The following is a description of a gene set: species: Homo sapiens Genes containing one or more binding sites for (ELF5) in their promoter regions (TSS -1000,+100 bp) as identified by GTRD version 20.06 ChIP-seq harmonization. Human Gene Set: ELF5_TARGET_GENES from publication Yevshin I, Sharipov R, Kolmykov S, Kondrakhin Y, Kolpakov F (PMID 30445619), and this is the list of marker genes: SPRYD3, MON2, PCDHGB1 (NCBI Gene Id 56104), CCDC90B, CCDC137, INTS13, DYNLRB2, FRG1, EXD3, LIMD1-AS1, PCYT1A, ZMAT3, TRIP4, TMEM87A, UBFD1, VTCN1, MRPL52, E2F6, SLC39A9, TBPL1, RAD50, SLC7A7, SMG7-AS1, PPP1R9B, ZBTB37, PYROXD2, GPBP1 (NCBI Gene Id 65056), PHF8, ZNF569, GANC, GIHCG, AXDND1, SCAND1, ATP2B4 (NCBI Gene Id 54594), PYROXD1 (NCBI Gene Id 79912), SUDS3, NAIF1, METTL6, GARS1, SNHG11, TUT1, ERP44 (NCBI Gene Id 23071), RPL37, CHCHD5, TMEM242, OXR1-AS1, EIF2S1, CDC42SE1, MYL12B, COX5B, TTC14, CDK18, DHX33-DT, UBC, SNRPB2, CDK6-AS1, DNAI1, CTDSP2, ADPRHL1, RPL29, MOCS3, ERBIN, DHFR2, LINC01132, KCTD5 (NCBI Gene Id 91152), LIMA1, THRB-AS1, LINC02518, CTSD, LYSMD1, ZNF823, DPM1, ESYT1, DMTF1-AS1, MAML3, SEC61G, ZNF383, CISD1, TBC1D9 (TBC1 domain family member 9), CPEB3, TRAPPC6B, HIGD2B, CCNT1, MEMO1, ACOX1 (NCBI Gene Id 8308), FRG1EP (NCBI Gene Id 102723390), ABCA15P, PPP4R3B, NFKB2, HARS1, INTS12, WDHD1, FRG1-DT, WDR43, NFE2L2, SMIM12, MIPEP, SMG8, XKR7, COX16, YWHAZ, SLX4IP, ZNF791, SLX9, THAP1, SF3A3, ACACA, ZNF668, SLC33A1, NOC3L, LSM5, ALG10B, C5orf34, SECISBP2, RND1, NCBP2AS2, UTP3, BMS1, ZFYVE26, FZD1, RPL11, COX7C, TRIP13, LFNG, PSCA, SMIM15 (NCBI Gene Id 649861), S100PBP, FBXL19, FGFR1OP2, ZMYND8, CCDC77, ULK4, NOP16, EAF1, CHCHD2, STX19, SPPL2A, GSTCD, GIN1, MROH6, SSBP1, SVIP, ARRDC1, DNLZ, GPR180, SEC61G-DT, SVOP, HSPE1-MOB4, CHFR-DT, YTHDF3-DT, CRTC2, UBE2L3, SHB, RBIS, CA13, RBM34, NOP10, MRPL1, FGGY, CCDC18-AS1, EIF1AD, COPS2, TNPO3, RABEPK, UBL7-DT, EOLA2, VPS25, LSG1, POLR2M, ATP6V0D1, RFX2, RN7SL832P, PTEN, CHN2, YARS1, FADD, SMCO4, BTK, ATP6V1H, STX3, MIR7-3HG, HARS2, GPR108, ZNF252P-AS1, CHFR, AQR, SLC25A25, COPB2-DT, RBSN, C19orf53, MRPL44, RNF146, MRPL24, RTRAF, EMC7, FRMD4A, GTSE1-DT, KIF3B, LRRC28, CDK6, RNU6-450P, NSUN3, CEP57 (centrosomal protein 57), RBM22 (RNA binding motif protein 22), GTF2H1, DDX56, TRIL, ZNF227, LYN, ESR2, GABARAP, RPL36A-HNRNPH2, EARS2, GPD2, SYS1, VPS37B (NCBI Gene Id 79720), ARL15, FBXL19-AS1, SLC2A1, IPO8, TAF2, RIMOC1, ZNF646, NUP42, UGGT1, GPX8, ERH, ELOVL6, MED23, FBXW7 (NCBI Gene Id 55294), RAPGEF3, HSH2D, TUBA1C, TSEN54, HPS1, HPS5, DYNLRB2-AS1, NCBP2, PTPN6, JRK, HNRNPF, LAS1L, SHKBP1, GABPB2, DELE1, FIBP, GRPEL2, HIKESHI, BANF1, SF3B2, CCDC57, RAB2A, TMEM242-DT, ATP6V0D1-DT, DNPEP, MEF2C-AS1, FAM76B (family with sequence similarity 76 member B), MED4, ANO10, MECOM, STMN3, SCNM1, PRORP, MCAT, TNRC18, EOLA2-DT, STARD10, PDCD2, ANKRD13A, GABPA, CNBD2, RPL6, USP3, EIF2AK1, PIGT, ENPP3, ZNF252P, PPP1CC, L1CAM, ANKRD49, PFDN5, MTRF1L, NOP2, RHOC, STX16-NPEPL1 (NCBI Gene Id 100534593), GALK2, SYS1-DBNDD2, ECT2, ELK3, C11orf52, SLC52A3, ARHGEF38, FFAR4, IL5, ATP5MJ, SLC2A9-AS1, SMARCD2, INVS, ERC2, GPC6, GTSE1 (G2 and S-phase expressed 1), NOB1, PNKD, SMC6, GJC1, SOCS4, GEN1, LINC02894, STX16, TM9SF2, VPS41, PPP4R3B-DT, MTFR2, TRAPPC9, MIR4453HG, MKRN3, GRB2, ZNF570, UBOX5, PSMA4, DHX33, MTPN, ZMAT2, LINC01547, TNIP1, KANSL3, PRSS27, DR1, VPS51, KRT8, MYL12-AS1, DHX8 (NCBI Gene Id 1659), WDR24, DOC2GP, NAA35, ITPKB, PSMA1, NUTM1, TRIM11, CCNI, WEE2-AS1, ZNF410, TTC14-DT, CCDC90B-AS1, INO80C, SACM1L, CBR4-DT, DPAGT1, NUP214, UBL7, SDHD, COPB2, MEF2C (myocyte enhancer factor 2C), RPS7, ARL14EP, FAM219A, ETFBKMT, YWHAB, TTC23 (tetratricopeptide repeat domain 23), DDX31, GARS1-DT, LINC01747, GFM2, AAMP, PPIP5K2, ADAM10, ZKSCAN2, IDH3A, MORF4L2-AS1, RPL36A, RPL32 (NCBI Gene Id 6161), SLC39A11, SLC16A3, MARCHF5, HSPE1, LINC01301, LUC7L, ANO6, RBM3, NUDT18, CASKIN2, KLHL20, HELB, NDRG1, CUL9, SNHG17, NAT1 (N-acetyltransferase 1), U2AF2, KDM5A, AP3B1, TTF1, INCENP, EMSY, SLC38A10, ZNF335, C8orf76, IFT140, WDR55, TDP1, DDX23, GAS5, BRD9, IKBKB, LTN1, NOXA1, LMX1B, VGLL4, ZNF846, MKKS, YAP1, PPP2R1A, ATP6V1D, FBXO34-AS1, SPRED2, TOR1AIP1, MX2, FBXO34, DMTF1, TRIP10 (thyroid hormone receptor interactor 10), AMN1, HSPD1, FASTKD5, SLC7A11, C11orf65, NFKB1, SELENOH, OXLD1, G2E3, HSPA8, TMEM123, NDUFAF4P1, CDIN1, NOL10, TIMM10, PLEKHA8P1, PLAC8, SLC25A14, PPP2R3C, SMG7, TPI1P2, MIR7-3, CARS2, MAN1A2, RPS19, PTPN11, ZNF490 (NCBI Gene Id 57474), EFCAB11 (EF-hand calcium binding domain 11), NSA2, LMAN2, ESRP2, EXOC2, MINCR, BBS4, GTF3C4, MORF4L2, GHR, PGM2, MRE11, GGA1, ZC3H10, LMX1B-DT, UBXN8 (UBX domain protein 8), ATP5PF, TIMM8B, ING1, DIABLO, PGBD4, ARHGEF12, MTMR9, ARPC3, VCPIP1, VAMP7, TRIM7-AS2, IKBKB-DT, WDR41, LNCATV (lncRNA negative regulator of antiviral signaling), PCLAF (PCNA clamp associated factor), RB1CC1, MIR4692, EPN3, CBR4, YTHDF3